Given this list of marker genes SIRT4, FIS1, HUWE1, TIMM17A, HAX1, HSPD1, SAMM50, TIMM9, GRPEL1, HSPA1L, TIMM8B (translocase of inner mitochondrial membrane 8 homolog B, NCBI Gene Id 91900), FBXO7, HSPA4, TIMM10, TOMM22, TIMM50, MTCH1, TIMM8A, BAG3, C11orf65, TIMM29, MTERF4, LMAN1, PARL, MFN2, UBL5, PINK1, TOMM40L, TOMM20, RHOU, CHCHD4 (coiled-coil-helix-coiled-coil-helix domain containing 4), DNLZ, MTCH2, NDUFA13, UBL4B, SREBF2, IMMP2L, BAG4, PAM16, HSP90AA1, BID, MFF, AIP, PRKN, TRMT10B, TOMM7, ATP5IF1, MIPEP, ABLIM3, BAP1, UBE2D3, AGK, DNAJC15, FBXW7, FZD5, ADCY10, IMMP1L, TOMM6, TIMM23B, DNAJC19, PIN1, PMPCA, TOMM40, GRPEL2, CSNK2A2, BCAP31, ROMO1, TIMM44, TOMM70, AIFM1, SREBF1, NPEPPS, RNF31, MICALL2, MGARP, GSK3A, UBE2L3, BNIP3L, TOMM34, TOMM5, LRRK2, MTX2, CDKN2A, TIMM21, LEPROT, TIMM17B, TIMM23, GFER, ATG13, PRKAA1, TIMM22, VPS11, UBE2J2, PITRM1, TSPO, HPS4, PMPCB, SAE1, SIAH3, HTRA2, ARIH2 (ariadne RBR E3 ubiquitin protein ligase 2), MTX1, RAC2, TIMM10B, USP36, TOMM20L (translocase of outer mitochondrial membrane 20 like), TIMM13, GDAP1, SH3GLB1 (SH3 domain containing GRB2 like, endophilin B1, NCBI Gene Id 51100), here is a description of the gene set: The process of directing proteins towards and into the mitochondrion, usually mediated by mitochondrial proteins that recognize signals contained within the imported protein. Human Gene Set: GOBP_PROTEIN_TARGETING_TO_MITOCHONDRION studied in species Homo sapiens